The following is a description of a gene set: Any process that modulates the frequency, rate or extent of mesodermal cell differentiation. Human Gene Set: GOBP_REGULATION_OF_MESODERMAL_CELL_DIFFERENTIATION studied in species Homo sapiens, and this is the list of marker genes: FGFR1, BMP4, BMPR1A, GJA1, MIR200C, SFRP2, DKK1, MESP1, MIR150, WNT3A